Given this list of marker genes Snap25, Doc2b, P2rx7, Atp2a2, Rims2, Unc13b, Cacna1a, Syt1, Syt7, Stxbp2, Rab3gap1, Rims1, Cadps, Stxbp1, Syt10, Stxbp3, Rab3a, Stx1b, here is a description of the gene set: Mouse Gene Set: GOBP_CALCIUM_ION_REGULATED_EXOCYTOSIS_OF_NEUROTRANSMITTER The release of a neurotransmitter into the synaptic cleft by exocytosis of synaptic vesicles, where the release step is dependent on a rise in cytosolic calcium ion levels. species: Mus musculus